Given this list of marker genes MELK, TRIP13, JPT1, PLXNA3 (NCBI Gene Id 8276), DCLRE1B, KIF4A, PIMREG, ACOT7, BIRC5, MBOAT2, FLNB, MRGBP, CDC25C, AURKA, here is a description of the gene set: species: Homo sapiens from publication López-Ríos F, Chuai S, Flores R, Shimizu S, Ohno T, Wakahara K, Illei PB, Hussain S, Krug L, Zakowski MF, Rusch V, Olshen AB, Ladanyi M (PMID 16540645) Most gene expression profiling studies of mesothelioma have been based on relatively small sample numbers, limiting their statistical power. We did Affymetrix U133A microarray analysis on 99 pleural mesotheliomas, in which multivariate analysis showed advanced-stage, sarcomatous histology and P16/CDKN2A homozygous deletion to be significant independent adverse prognostic factors. Comparison of the expression profiles of epithelioid versus sarcomatous mesotheliomas identified many genes significantly overexpressed among the former, including previously unrecognized ones, such as uroplakins and kallikrein 11, both confirmed by immunohistochemistry. Examination of the gene expression correlates of survival showed that more aggressive mesotheliomas expressed higher levels of Aurora kinases A and B and functionally related genes involved in mitosis and cell cycle control. Independent confirmation of the negative effect of Aurora kinase B was obtained by immunohistochemistry in a separate patient cohort. A role for Aurora kinases in the aggressive behavior of mesotheliomas is of potential clinical interest because of the recent development of small-molecule inhibitors. We then used our data to develop microarray-based predictors of 1 year survival; these achieved a maximal accuracy of 68% in cross-validation. However, this was inferior to prognostic prediction based on standard clinicopathologic variables and P16/CDNK2A status (accuracy, 73%), and adding the microarray model to the latter did not improve overall accuracy. Finally, we evaluated three recently published microarray-based outcome prediction models, but their accuracies ranged from 63% to 67%, consistently lower than reported. Gene expression profiling of mesotheliomas is an important discovery tool, but its power in clinical prognostication has been overestimated. Human Gene Set: LOPEZ_MESOTELIOMA_SURVIVAL_TIME_UP Top genes higher expressed in short term mesothelioma survivors.